Given this list of marker genes SPP1 (NCBI Gene Id 6696), F7, PDE2A, CYP1A1, TIPARP, SLC46A3, AHR, here is a description of the gene set: species: Homo sapiens Human Gene Set: GOBP_RESPONSE_TO_2_3_7_8_TETRACHLORODIBENZODIOXINE Any process that results in a change in state or activity of a cell or an organism (in terms of movement, secretion, enzyme production, gene expression, etc.) as a result of a 2,3,7,8-tetrachlorodibenzodioxine stimulus.